The following is a description of a gene set: Enlarged and tortuous veins. Varicose veins Human Gene Set: HP_VARICOSE_VEINS species: Homo sapiens, and this is the list of marker genes: EPHB4, COL3A1, G6PC3, TBX1, PIEZO1, SLC29A3, GBA1 (glucosylceramidase beta 1), SLC12A3, UFD1, ANGPT2, VHL, HIRA, NOTCH3, ARVCF, SMAD2, FLT4, SMAD3, COMT, GP1BB, GJC2, ENG, AEBP1, RASA1 (NCBI Gene Id 5921), TGFB2 (NCBI Gene Id 7042), JMJD1C, SEC24C, FIBP, CLCNKB, FOXC2, KIF5A, PIK3CA, RREB1